Given this list of marker genes RRM1, KCNA5, MIR515-1, MIR222, EGFR, CCND1, LSM10, KMT2E, PLRG1, PTENP1-AS, MIR519D (NCBI Gene Id 574480), PLCB1, MBLAC1, CCND3, LSM11, AKT1, DDR2, MDM2, DDX3X, MIR372, CCNE1, CYP1A1, RRM2, MIR221, MTBP (MDM2 binding protein), ANXA1, FGF10 (fibroblast growth factor 10), ADAMTS1, MIR520H, EIF4G1, STIL, TFDP1, AIF1, MIR495, MIR29A, RGCC, CENPJ (centromere protein J), CDC6, CUL4A, MIR520A, CCNE2, STOX1, RPTOR, SASS6, ADAM17, UBE2E2 (NCBI Gene Id 7325), ANKRD17, RDX, CDK10, CCND2, MIR208A, MEPCE, TERT, CPSF3, CUL4B, MIR214, here is a description of the gene set: studied in species Homo sapiens Human Gene Set: GOBP_POSITIVE_REGULATION_OF_G1_S_TRANSITION_OF_MITOTIC_CELL_CYCLE Any signaling pathway that increases or activates a cell cycle cyclin-dependent protein kinase to modulate the switch from G1 phase to S phase of the mitotic cell cycle.